Given this list of marker genes Nlgn1, Stx1b, Dtnbp1, Baiap3, Gper1, Snca, Bglap2, Rab3gap1, Gpr158, Unc13a, Bcl2l1, Htr2c, Micu3, Stxbp1, Slc18a3, Syt1, Sphk1, Cacna1b, Bglap, Tacr2, Ptger4, Slc4a8, Kmo, Adora2a, Dnm1l, Stx1a, Cacna1d, here is a description of the gene set: species: Mus musculus Any process that activates or increases the frequency, rate or extent of the regulated release of a neurotransmitter. Mouse Gene Set: GOBP_POSITIVE_REGULATION_OF_NEUROTRANSMITTER_SECRETION